The following is a description of a gene set: studied in species Homo sapiens Genes predicted to be targets of miRBase v22 microRNA hsa-miR-499a-5p in miRDB v6.0 with MirTarget v4 prediction scores > 80 (high confidence targets). Human Gene Set: MIR499A_5P from publication Chen Y, Wang X (PMID 31504780), and this is the list of marker genes: ANKRD49, SECISBP2L, MAMDC2, SH3KBP1, SRI, PEDS1-UBE2V1, LIPA, SEC11A, NOVA1, RAB5C, KLHL42, SMC6, SIAH3, TMEM202, THBS2, GPR180, PRPSAP1, VAV3, VPS13A, KLF7, COLQ, SYBU, YIPF6, ADCYAP1, HNRNPC, H2AZ1, FBXW8, EBAG9 (NCBI Gene Id 9166), RIMS1, DGCR8, SEH1L, LRRTM1, ARHGAP12, PRKAR1A, HSD17B13, LAMP3, SEC14L1, SMIM15, ARGLU1, RMDN3, LIN28B, KCNN3, TNFAIP8L3, RCOR3, DNAJC25, PTPRG, DCP2, SPRED1, SDC2, EPB41L2 (erythrocyte membrane protein band 4.1 like 2), MPZL2, SEMA3A, PCDHB11, PEG3, ANTXR2, EDAR, HP1BP3, TRUB1, GATA3, DDX1, JADE1, E2F3, ANKRD40, ELAVL4, PLAG1, SLC30A4, MYEF2, LIMA1, USP45, TSPAN12, EYA4, TVP23C, NDUFA5, UBE2V1, SLC12A2, ERCC4, ATF2, YBX1, RRAGB, PNISR, REEP1, COL5A2, DCAF5, PTBP2, PCDHB13, OMG, PPP4R3B, CNOT9, IKZF2, LRCH2, LRRC8C, PAPOLA, NOCT, DSG2, STC1, SLC9C1, NR3C1, AHCTF1, ZUP1, RSBN1, FNBP4, EIF4G2, RNF145, TUT7, NRARP, MED13, CREBZF, VCPIP1, CNTN5, SNRK (SNF related kinase), ST8SIA4, IMPG2, KPNA3, REST, MTERF1, SMCO1, ARB2A, PTCH1, SOX5, OSBPL1A, ZSWIM7, EML4, PLN, ELMOD2, SLC6A13, KDM7A, CACNB2, TESK2, FBN1, SNX2, PTAR1, UBE2V2, CPSF2, UQCC6, FOXN2, EPM2AIP1 (NCBI Gene Id 9852), SCN4A, RALYL, DEPDC1B, PTP4A1, PHLDA2, ASPH, KIF13B, PTBP3, WDR41, SOS2, ST7, PDCD4, SOX6, TMBIM6, KCNA4, RCN2, SAMD8, TNFSF10, MARS2, CERT1, GDF9, TGFA, COMT, RGS21 (NCBI Gene Id 431704), MAP2, SKP1, TMEM100, FNIP1, ADAM10, MAPK6, CNOT6L, MFSD14A, FOXP2, ZNF217 (NCBI Gene Id 7764), XRN1, PPP3CA, HDAC9, MCU, MEIS3